The following is a description of a gene set: Human Gene Set: GOBP_POSITIVE_REGULATION_OF_CHONDROCYTE_PROLIFERATION Any process that increases the frequency, rate or extent of the multiplication or reproduction of chondrocytes by cell division, resulting in the expansion of their population. A chondrocyte is a polymorphic cell that forms cartilage. studied in species Homo sapiens, and this is the list of marker genes: LTF, SIRT6, PBXIP1, COMP, SOX9, SIX2, LEF1, MUSTN1